Given this list of marker genes Apoh, Anxa2, Plau, Plaur, Klkb1, Serpinf2, Hpn, Clec3b, H2bc1, Fgg, Tmprss9, Dhcr24, Serpine1, Eno1b, Serpine2, Eno1, S100a10, Plgrkt, Plat, Thbs1, Fga, Ctsz, Cpb2, Pgk1, Meltf, F12, Fgb, F11, here is a description of the gene set: The process in which inactive plasminogen is processed to active plasmin. This process includes cleavage at an internal Arg-Val site to form an N-terminal A-chain and C-terminal B-chain held together by a disulfide bond, and can include further proteolytic cleavage events to remove the preactivation peptide. studied in species Mus musculus Mouse Gene Set: GOBP_PLASMINOGEN_ACTIVATION